The following is a description of a gene set: Human Gene Set: GOBP_POSITIVE_REGULATION_OF_RESPONSE_TO_BIOTIC_STIMULUS studied in species Homo sapiens Any process that activates or increases the frequency, rate, or extent of a response to biotic stimulus., and this is the list of marker genes: IPO5, USP15, FCN3, TMEM126A, TRIM56, MIR210 (NCBI Gene Id 406992), TLR10, TKFC, XRCC6, GPR108, LTF, MIR146A, BMP6, ERBIN, USP27X, TRIM15, BCL10, FBXL2, NFKBIL1, RNF125, IFIH1, MIR520E, RFTN1, NLRP6, HSPD1, MAPKAPK3, TRIM5, ABHD17A, CARD8, SQSTM1, IFI16, CD300A, TICAM2, FLOT2, CARD9, TAB1 (TGF-beta activated kinase 1 (MAP3K7) binding protein 1), TLR4, LBP, HSP90B1, BTK, WASHC4, TAX1BP1, CADM1, TRIM31, RAET1G, HMGB1, NPLOC4, NOD1, CD1D, LAG3, LACC1, GPS2, RBM14, PUM2, AP3B1, ZDHHC9, NR1H4, RASGRP4, IKBKE, SIGLEC16, IFNB1, CPT1A, TRIM6, CD226, STAT5A, SFPQ (NCBI Gene Id 6421), POLR3F, MIR19A, CTSS, NLRP2B, C1QBP, MARCHF5, BIRC3, SASH1, DAB2IP, GPATCH3, LYPLAL1, PPP2CA, TARBP2, CGAS, MIR520B, PRKAA1, TRIM3, S100A14, PRKCA, PLA2G5, PARP9, AIM2, IRF3, TIFAB, FFAR2, RNF144A, BIRC2, PVR, TREX1, XRCC5, UBE2K, KCNK13, MAP2K6, ZDHHC4, NR1H3, CLPB, TLR7, HLA-G, TNFAIP3, YWHAE, OGT (NCBI Gene Id 8473), PHB1, GRAMD4, ZNRF4, PAK1 (p21 (RAC1) activated kinase 1), LRRC19, SPSB3, DHX9, SYK, IFI35, RAB11FIP2, ELP6, RIPK2, EIF2AK2, PARP1 (poly(ADP-ribose) polymerase 1), HMGB2, LGR4, PIK3AP1, DHX58, NLRP10, LGALS9, CCL5, DDX60, PJA2, FYN, GKN2, NLRC3, UFD1, MED1, LRCH4, POLR3G, HLA-F, KAT5, RNF170, KLRC2, PYDC1, TLR5, AURKB, FCN2, ZC3HAV1, IL17A, PAK2, IKBKB (NCBI Gene Id 3551), CD300LF, PTPN22, IRF5, TXK, GBP5, PCBP2, PYHIN1, IL21, ZDHHC1, HSPA8, NAIP, PLCG2 (phospholipase C gamma 2), FBXO38, CLEC6A, UNC93B1, PIK3R1, TBK1, EMILIN2, TLR9, SLC15A2, MAP3K7, TNIP2, RELA (RELA proto-oncogene, NF-kB subunit), RNF135, CD274, DDX41, TLR2, NR1D1, RSAD2, MIR708, LILRA2, TYROBP, HSPA1B, IRAK4, SRC, KLRK1, ECSIT, SLC46A2, BECN1, LYN (LYN proto-oncogene, Src family tyrosine kinase), LATS1, CLNK, POLR3D, KCNK6, CSNK1A1, TIFA, KLRC4, PSPC1, TRAF3, TSPAN6, GSDME, TLR8, INAVA, MNDA, NOP53, USP17L2, MEFV, MIR149, LRRC14, KLK5, CD180, NONO, GDI1, IRF1, XIAP, CYLD, TLR1, MIR17 (microRNA 17), FOSL1, DHX33, ALPK1, SH2D1A, CPTP, RNF39, MIR140, PRKD1, CRTAM, PYDC5, BPIFB1, ZBP1, SLAMF6, TRAF6, ESR1, HRG (NCBI Gene Id 3273), MMP12, YWHAG, HDAC6, P2RX7 (NCBI Gene Id 5027), STMP1, IRGM, NECTIN2, SH2D1B (SH2 domain containing 1B), CYBA, RNF115, BRCC3, POMC, SEC14L1, KCNJ8, ZDHHC5, RNF185, RPS6KA3, S100A9, MIR4691, RASGRP1, CD14, MIR20A, RPS19, TICAM1 (TIR domain containing adaptor molecule 1), SLC22A13, BANF1, NEK7, TNF, PPT1, IRF7, RIOK3, TLR3, LILRA4 (leukocyte immunoglobulin like receptor A4), EREG, MATR3, IL12B (interleukin 12B), TRIM65, CD36, PUM1, TYRO3, OTUD4, EPG5, IRAK1, SPI1, AKT1, NAGK, GBP2, MIR200B, SMPDL3B, RBM47, TRIL, CHUK, NCR3, SIN3A, USP50, HAVCR2, ANKRD17, KIR2DS2 (NCBI Gene Id 3807), TNIP3, ARRB2, LY96, TOMM70, RTN4, IFNK, OAS3, ACOD1, CD160, MAPKAPK2, CACTIN, PHB2, SCARA3, TRIM32, ZDHHC3, RAB7B, KLRD1, TRAF3IP3, TASL, MR1, LATS2, EMILIN1, PRKDC, KIR2DL4, TLR6, ZDHHC18, LY86, MIF, IL17F, SIRT2, TRIM62, MAVS (NCBI Gene Id 78993), TRIM11, COLEC11, VAV1, PPP6C, NOD2, CLEC4E, TRIM25, HCK, HCFC2, OAS1, CLEC7A, NFKBIA, NFKBIZ, IRAK2 (interleukin 1 receptor associated kinase 2), CREBBP, MYD88, POLR3C, WDFY1, HLA-E, HSP90AA1, RIGI, MAPK8, ABHD8, NLRX1, COLEC12, IRAK3, LAMP1, SCIMP, FADD, ZNRF1, USP29, HLA-DRB1, ZCCHC3, PGC, CAV1, COLEC10, EP300, PDPK1, TREML4, REG3G, CCDC134, F2RL1, HLA-DRB3, SLC19A1, SMPDL3A (NCBI Gene Id 10924), NLRP3, TIRAP, KLRC3, MMRN2, PELI1, SLC15A4, MBL2, DDX3X, LAMP2, KLHL22, WNT5A, ATAT1, MIR200C, KLK3, APPL1, NMI, PLSCR1, KLK7, KLRC1, SARM1, PTPRS, FCN1, IL18RAP, NAGLU, MFHAS1, TNIP1, NLRC5, S100A8, PYCARD, HSPA1A, FCRL3, GFI1, UBQLN1, PRKCE, NLRC4, LETMD1, OASL, OTULIN, FLOT1, IL12A, POLR3B, PQBP1, HEXIM1, AKIRIN2, APPL2, NLRP1, HPX, TRIM41, STAT5B, CASP6, PYDC2, SLC15A3, KLRC4-KLRK1, PTPN11, PAK3 (p21 (RAC1) activated kinase 3), RAET1E, ZDHHC12, ARG1, GRN, ZNFX1, TREM2, NINJ1, AP1G1, AARS2, LSM14A, APP, FPR2, CASP1, ITCH, ADAM8, MARK4, RNF34, STING1, IRF4